The following is a description of a gene set: The transformation of benign lesions to malignant tumours is a crucial aspect of understanding chondrosarcomas, which are malignant cartilage tumours that could develop from benign chondroid lesions. However, the process of malignant transformation for chondroid lesions remains poorly understood, and no reliable markers are available to aid clinical decision-making. To address this issue, we conducted a study analysing 11 primary cartilage tumours and controls using single-cell RNA sequencing. By creating a single-cell atlas, we were able to identify the role of endoplasmic reticulum (ER) stress in the malignant transformation of conventional central chondrosarcomas (CCCS). Our research revealed that lower levels of ER stress promote chondrosarcoma growth in a patient-derived xenograft mouse model, while intensive ER stress reduces primary chondrosarcoma cell viability. Furthermore, we discovered that the NF-?B pathway alleviates ER stress-induced apoptosis during chondrosarcoma progression. Our single-cell signatures and large public data support the use of key ER stress regulators, such as DNA Damage Inducible Transcript 3 (DDIT3; also known as CHOP), as malignant markers for overall patient survival. Ultimately, our study highlights the significant role that ER stress plays in the malignant transformation of cartilaginous tumours and provides a valuable resource for future diagnostic markers and therapeutic strategies. Identified by the specific marker COL10A1, as well as PTHIR and IHH which have been described to regulate chondrocyte hypertrophic differentiation through a negative feedback loop. from publication Su Z, Ho JWK, Yau RCH, Lam YL, Shek TWH, Yeung MCF, Chen H, Oreffo ROC, Cheah KSE, Cheung KSC (PMID 38267611) studied in species Homo sapiens Human Gene Set: SU_HO_FOETAL_FEMUR_C2_HYPERTROPHIC_CHONDROCYTE, and this is the list of marker genes: PAMR1, GPSM1, FOXA3, MTSS2, P3H2 (NCBI Gene Id 55214), S100A1, SCIN, CCNH, PLCD1, PIEZO1, ACAT2 (NCBI Gene Id 39), TMEM101, STK38L, F13A1, RNF126, IMPA1, SLC25A1, RHOD, NDRG1, ROMO1, TIFA, CHCHD2, EZR, UBE2D1, IER3IP1, SLC13A5, TAF10, UQCRQ, WDR1, RCN1, GNAS, PAPOLA, RAPH1, ZNF525, MAP1LC3B, TSC22D4, KCNK5, SLIRP, HLA-DRB1, S100P, LNPK, RIOK3, SLC16A1, NPEPPS, CITED2, COLGALT1, P4HB (NCBI Gene Id 94756), CHSY1, SEMA3D, SH3BGRL3, ACLY, PDPN, HMGCR, PDCD10, WSB1, RXRA, MFSD10, S100A10, TMEM119, COX7A1, FOXO4 (NCBI Gene Id 4303), ERO1A, IGF1R, SSR3, CLTB, ZFAND2A, ZFYVE21, AP1S3, NDUFB8, BMP2, LSM12, PINK1, KDELR2, RABGGTB, NUPR1, ANXA5, PPA1, XBP1 (X-box binding protein 1, NCBI Gene Id 7494), GPC1, TALDO1, LDHA, SSU72, LGMN, SLC8A3 (NCBI Gene Id 90450), SPOCK1, PTH1R, NDUFAB1, CCND1, GYG1, SIRT2, ARHGAP18, MSMO1, FGFR3, TMBIM1 (transmembrane BAX inhibitor motif containing 1), SLC2A1, RPS17, TMED5, CDV3, CDC42, VLDLR, UBC, STC2, NRN1, SPSB1, COL10A1, SAP18, PANX3, PTGES, BZW2, RCOR2, SMPD3, HOXC6, SMIM5, ORMDL2, LRRC1, RTRAF (RNA transcription, translation and transport factor), PPP2CB, TLN2, PITPNC1, SLC38A2, SLC1A5, NIBAN2, CCDC107, PCBP1, CEBPB, COPZ2, FABP3, SCUBE1, TXN, WNT5A, HSPA6, SCD (NCBI Gene Id 6319), VAV3, PTS, SLC38A4, SLC25A36, CRYAB, AGPAT2, FGFBP2, BOLA3, BHLHE40, ATP2C1 (ATPase secretory pathway Ca2+ transporting 1), RHOA, SLC25A4, TPD52, CRISPLD2, SLC5A3, PLOD3, CXXC5, NEBL, STRAP, ANGPTL2, TOB1, PIM3, LGALS3, CD109, KLF2, COMP, TMED3 (transmembrane p24 trafficking protein 3), LOX, HAS2, GNPTAB, NDUFB7, TTLL7, STK39, FOS, SNTB2, CSRP2, EFHD1, TMX1, TXNDC17, SCRG1, CD24, COX17, NDUFA11, C1QTNF3, NINJ2, GCNT1, MEA1, NPR3, PCOLCE2, ZFAND5, TPM2, PANK3, COX6A1, SGMS2, DIO2, ARSI, SLC6A8, GLS, DOK5, ATRNL1 (NCBI Gene Id 26033), CKB, CDKN1A, MXRA7, HIGD1A, IL17B, SERINC5, ANKRD37, FURIN, BNIP3, CCDC88A, PPFIBP1, ADK, LDLRAD4, MVD, CLEC3A, CAB39, LOXL3, VIT, NOG, ELOVL1, CD44, ENO2, ATP1B3, RER1, DDR1, TWSG1, PPDPF, CDKN1C, LOXL2, RORA, GPC3, HAGH, PHTF2, ERG28, SLC18A2, JPH1, PDCD5 (NCBI Gene Id 9141), LRRC28, LOXL4, ALPL, SERPINI1, MATN3, SQLE, TRIB2, AVPI1, PGAM2, DBI, PDE4DIP, SERPINA1, IL6R, OAZ1 (ornithine decarboxylase antizyme 1), DDIT4L (NCBI Gene Id 115265), NAAA, C4orf3, TMEM123, CLIC4, EIF1AX, SNX18, PHOSPHO1, NGEF, CA2, WNT4, MFGE8, IHH, TMED10, CAPS, CYSTM1, ARPC3, KISS1R, RRAGD, LPL, BMP6, TSC22D3, AKT1, SLC7A5, RRAS2, NYAP1, SPTLC2, RELT, ARHGEF37, VDAC1, MRPS6, DACT3, AP1AR, MEF2D (NCBI Gene Id 4209), SMOC2, SNORC, ATP5MF, BPNT2, RPSA, WSB2, RNF181, NIBAN1, SOX8, VOPP1, ERRFI1, HSPH1, YWHAQ, DHCR7, DSTN, UQCR11, MGST1, SLC38A3, OSBPL1A, SPPL2A, HAPLN1, ZBTB10, KDELR3, SH3BP2, ASS1, IER3, GSN, KRAS, PLXNB1, MELTF, SRP14, KLHL21, UFD1, WNT11, RAB18, MYDGF, PCSK6, CDC42EP3, JOSD2, KCNQ1OT1, ARHGAP44, TFRC, MXI1, DNAJA4, CLIC3, PDLIM4, RPL37A, PSMB3, CTSZ, SSR4, SLC44A2, PHLDA3, MTHFD2, CPM, NFAT5, CA12, TSPAN13, SRI, KLHDC3 (NCBI Gene Id 116138), KLF5, CRISPLD1, NRCAM (NCBI Gene Id 4897), TIMP4, TBCA, ATP5F1E, TNFRSF12A, PSTPIP2, SPON2, ATP5MK, PAPSS2, CMTM8, YIF1A, BZW1, PPIC, JARID2